Given this list of marker genes ANKS1B, MGP, RTN4, MET, DDR1, STAB2, COL6A2, SHC1, GRK3, COL7A1, PIM1, C6, SRPK2, MFAP5, MCM7, FZD1, CCN1, CTSV, PLXNB3, LGALS1, P3H3, BCL2A1, BMF, SMO, HIPK2, FASTK, IL12RB1, PPP2R1A, L1CAM, ANKS1A, F2R, TMEM45A, BID, NAIP, BMP1, MAP4K4, CSNK1E, PTK7, PTPRM, BNIP3, ELN, PDCD6IP, PTPRF, GAS2, ITGB5, CCBE1, RPS6KL1, NRCAM, BTK, LGALS3BP, TSPAN9, ADRA1A, COL4A6, NME6, NLGN4X, IL3RA, WNK1, TSPAN33, FAT1, STK32C, SLC1A4, SH2D4A, LRRC66 (NCBI Gene Id 339977), CEACAM1, PLXNA2, LTBR, LGI3, TNFRSF1A, DAP3, HAPLN3, LZTR1, SMAD3, PLAGL1, CAMK1, here is a description of the gene set: from publication Lee JH, Horak CE, Khanna C, Meng Z, Yu LR, Veenstra TD, Steeg PS (PMID 18245461) Up-regulated genes displaying alternative splicing in MDA-MB-435 cells (breast cancer) whose metastatic potential has been reduced by expression of NME1. The role of Gemin5 in alternative mRNA splicing, tumor cell motility, and proteomic instability was investigated. Isotope Capture Affinity Tag proteomic analysis was conducted on MDA-MB-435 tumor cells transfected with either a control vector (C-100) or the Nm23-H1 metastasis suppressor (H1-177). Ingenuity pathway analysis revealed that RNA posttranscriptional processing was the most prominent class of differentially expressed proteins. Within this category, overexpression of Acinus1, Poly(a) binding protein, HNRPA2B1, Bop1, and Gemin5 was confirmed in less metastatic H1-177 cells. Overexpression of the latter four proteins was also observed in the lower metastatic antisense Ezrin transfectant of a murine osteosarcoma model system, confirming the general relevance of the trends. Gemin5, a component of the spliceosomal complex, was chosen for further study. Analysis of global mRNA splicing by SpliceArray chips revealed that genes were differentially spliced in C-100 compared with H1-177 cells; transient transfection of gemin5 into C-100 cells restored the splice pattern to that of H1-177 cells. Alternative splicing patterns for the engulfment and cell motility 1 and thrombospondin genes were confirmed by semiquantitative reverse transcription-PCR. Gemin5 overexpression coordinately reduced C-100 cell motility by 50%, and siRNA-mediated reduction of Gemin5 expression increased the motility of H1-177 cells by 2-fold (P < 0.004). The data provide the first demonstration that alterations in the expression of a spliceosome protein can effect both specific splicing events and tumor cell motility. The data also show that changes in mRNA splicing patterns accompany metastatic progression, which may contribute to proteome instability. species: Homo sapiens Human Gene Set: LEE_METASTASIS_AND_ALTERNATIVE_SPLICING_UP